Given this list of marker genes Hspa8, Vdac2, Slc9a1, Acaa2, Bloc1s2, Slc25a31, Bok, Erbb3, Gsk3b, Fzd9, Eya2, Chchd10, Rhot1, Hip1r, Mylk3, Jam3, Bak1, Stpg1, Tmem14a, Nrg1, Bcl2l11, Rhot2, Slc25a4 (NCBI Gene Id 11739), Atf2, Bid, Gclc, Mul1, Erbb2, Siva1, Mpv17l, Tmem102, Slc25a5, Fxn, Zfp13, Bnip3, Gsk3a, Spg7, Bnip3l, Bax, Ier3, Bcl2l1, Trp53, Slc35f6, Ppif, Atp5if1, Laptm5, here is a description of the gene set: Any process that activates or increases the frequency, rate or extent of the passage or uptake of molecules by a membrane. species: Mus musculus Mouse Gene Set: GOBP_POSITIVE_REGULATION_OF_MEMBRANE_PERMEABILITY